Given this list of marker genes SLC2A2, here is a description of the gene set: species: Homo sapiens Reactome Pathway: Defective SLC2A2 causes Fanconi-Bickel syndrome (FBS) part of: SLC transporter disorders The reversible facilitated diffusion of fructose, galactose, and glucose from the cytosol to the extracellular space is mediated by the SLC2A2 (GLUT2) transporter in the plasma membrane. In the epithelial cells of the small intestine, the basolateral localisation of SLC2A2 enables hexose sugars derived from the diet (and taken up by SLC5A1 and SLC2A5 transporters into cells) to be released into the circulation. SLC2A2 is a low affinity glucose transporter expressed mainly in the kidney, liver and pancreatic beta-cells. In beta-cells, it functions as a glucose-sensor for insulin secretion and in the liver, it allows for bi-directional glucose transport. Defects in SLC2A2 can cause Fanconi-Bickel syndrome (FBS; MIM:227810), a rare but well-defined disorder characterised by glycogen accumulation, proximal renal tubular dysfunction, and impaired utilisation of glucose and galactose.